The following is a description of a gene set: Genes predicted to be targets of miRBase v22 microRNA hsa-miR-4713-3p in miRDB v6.0 with MirTarget v4 prediction scores > 80 (high confidence targets). from publication Chen Y, Wang X (PMID 31504780) Human Gene Set: MIR4713_3P species: Homo sapiens, and this is the list of marker genes: H2BC5, FGD6, DOK1, PTDSS1, DUX4, SLC25A23, KCNN3, SRXN1, PSMD14, ELP5, HNRNPA0, UPP2, TARP, GALNT10, GINS4, MKRN1, ATP2B1, F8, LMCD1, MYEF2, CIBAR1, COL27A1, CERCAM, TSTD2, MYCBP, ACYP2, ZNF215, SYNCRIP, KCNJ6 (potassium inwardly rectifying channel subfamily J member 6), MYOM3, ERP44, GSG1, ITIH6 (NCBI Gene Id 347365), KDSR, CLCC1, CD4, LMO4, ADGRL3, LRRC27, GSTA4, IQCH, B3GAT1, RIPOR2